Given this list of marker genes Chrnb2, Chrna7, Chrnb4, Chrna3, Chrm3, Chrnb1, Chrna1, Chrna4, Chrnd, Chrnb3, Ache, Chrna5, here is a description of the gene set: studied in species Mus musculus Mouse Gene Set: GOMF_ACETYLCHOLINE_BINDING Binding to acetylcholine, an acetic acid ester of the organic base choline that functions as a neurotransmitter, released at the synapses of parasympathetic nerves and at neuromuscular junctions.